Given this list of marker genes PLAG1, CYP17A1, PHKB, CYB5A, PPARG, LMNA, PHKA2, IGF2, PHKG2, CDKN1C, AIP, GPR101, HMGA2, ANTXR1, here is a description of the gene set: Dysmenorrhea species: Homo sapiens Pain during menstruation that interferes with daily activities. Human Gene Set: HP_DYSMENORRHEA